The following is a description of a gene set: Human Gene Set: GOBP_PROTEIN_O_LINKED_GLYCOSYLATION_VIA_SERINE studied in species Homo sapiens The glycosylation of protein via the O3 atom of peptidyl-serine, forming O3-glycosyl-L-serine; the most common forms are N-acetylgalactosaminyl, mannosyl, galactosyl, and xylosyl serine., and this is the list of marker genes: MGAT5B, GALNT16, POGLUT3, GALNT1, POGLUT1, POGLUT2, GALNT13, GALNT3, GALNT2, GALNT4